Given this list of marker genes PDHX, NDUFA4, LONP1, PET117, MECP2, DLAT, PDHA1, here is a description of the gene set: Human Gene Set: HP_ABNORMAL_CSF_PYRUVATE_FAMILY_AMINO_ACID_CONCENTRATION Any deviation from the normal concentration of pyruvate-family amino acids in the cerebrospinal fluid. species: Homo sapiens Abnormal CSF pyruvate family amino acid concentration